Given this list of marker genes IGHM, IGHG3, IGHD, JCHAIN, IGHG1, IGHA1, IGHG4, IGHE, IGKV3-20, PIGR, IGHG2, IGHA2, here is a description of the gene set: Human Gene Set: GOCC_IMMUNOGLOBULIN_COMPLEX_CIRCULATING An immunoglobulin complex that is secreted into extracellular space and found in mucosal areas or other tissues or circulating in the blood or lymph. In its canonical form, a circulating immunoglobulin complex is composed of two identical heavy chains and two identical light chains, held together by disulfide bonds. Some forms of are polymers of the basic structure and contain additional components such as J-chain and the secretory component. studied in species Homo sapiens